Given this list of marker genes AQP1, HEYL, SLC22A1, PKD1, DLL1, NOTCH2, SLC22A6, ACAT1, AQP11, here is a description of the gene set: Human Gene Set: GOBP_PROXIMAL_TUBULE_DEVELOPMENT The process whose specific outcome is the progression of the proximal tubule over time, from its formation to the mature structure. In mammals, the proximal tubule is a nephron tubule that connects Bowman's capsule to the descending thin limb of the loop of Henle. It has a brush border epithelial morphology. studied in species Homo sapiens